Given this list of marker genes Zfp451, Kmt2a, Ddx19b (DEAD box helicase 19b), Mrpl19, Gsdmc4, Chic1, Lyve1, Aldh18a1, Dsg1c (desmoglein 1 gamma), Kcnip2, Tceal8, Myh9, Wfikkn2, Slc40a1, L1cam, Usf2, Selenoo, Them7, Pus1, Wfdc17, Fam124a, Ppm1g, Med19, Crbn, Smad9, Abcc5 (ATP-binding cassette, sub-family C member 5), Akap9, Zswim6, St8sia5, Tox, C3ar1, Ypel5, Foxm1, Prune2, Epm2aip1, Amigo1, Tmed1, Aipl1, Ppp1r14d, Rlim, Wfdc18, Cybb, Cask, Neurod1, Gabarapl2, Pikfyve, Txnip, Npm1, Slc23a2, Plce1, here is a description of the gene set: from publication Chen Y, Wang X (PMID 31504780) Mouse Gene Set: MIR_6366 Genes predicted to be targets of miRBase v22 microRNA mmu_miR_6366 in miRDB v6.0 with MirTarget v4 prediction scores > 80 (high confidence targets). species: Mus musculus